The following is a description of a gene set: Genes predicted to be targets of miRBase v22 microRNA hsa-miR-6891-5p in miRDB v6.0 with MirTarget v4 prediction scores > 80 (high confidence targets). Human Gene Set: MIR6891_5P studied in species Homo sapiens from publication Chen Y, Wang X (PMID 31504780), and this is the list of marker genes: YIPF6, PPP1R16B (protein phosphatase 1 regulatory subunit 16B), ABLIM3, PIM1, RUNDC3B, VAX1, ADPRHL1, TOB1, CELF4, RTKN2, PICALM, DNA2 (NCBI Gene Id 1763), MEF2D, NRM, SLC9A5, MIB1, RELN, UBR7, PAFAH1B2, ATP6V1A, MAX, GSPT1, ARMC7, LRRC70, VAV3, STK40, GMFB, MTCL2 (NCBI Gene Id 90072), TRIM67, UHRF1, RUSC1 (NCBI Gene Id 23623), RGPD6, RETREG3, JCAD, SHISA6, KMT2A, PTGER3, CLCN3 (NCBI Gene Id 133073), TMEM184B, RGPD5, AUNIP, UBE2Q1, TMEM35B, TAOK1, OXSR1, SMG5, COBL, APOBEC3H, ZDHHC9, PRRC2B (proline rich coiled-coil 2B), EPHA7, FBP1, CORO2B, CDYL2, NWD2, VSX1, FRYL, MCU, RIMS3, PRH2, CD55 (NCBI Gene Id 1604), NUFIP2, OSM, ZNF444, PHACTR4, ZKSCAN1, HYAL4, TOPORS, EN2, CEP170, NHEJ1, MYO1D, CLUL1, SPOCK1, PRTG, ZPBP2, ZBTB7A, CFLAR, EPM2AIP1, HNRNPH1, G6PC1, RBIS, SON, RNF5, FHIP1A, MAL2, MECP2, EGR3 (early growth response 3), CHD4, LGI2, AURKA, SLC24A4, PYCR2, PPP6C, SLC25A35, CBL, LCE2C, KAZN, FKTN, APH1A, RAB8A, UBTD2, MYO6, TACR1, SNX16, SNTA1, CNOT6L, ARID1A, SORCS1, SEMA3F, USP32, ZNF391, NOVA2, PRR13, PLEKHS1, C2CD5, RGPD8, RNF125, FCHSD2, SDK1, KAT6A, VAMP1, ARPP19, PCDH19